The following is a description of a gene set: species: Homo sapiens Human Gene Set: AIZARANI_LIVER_C33_STELLATE_CELLS_2 from publication Aizarani N, Saviano A, Sagar, Mailly L, Durand S, Herman JS, Pessaux P, Baumert TF, Grün D (PMID 31292543), and this is the list of marker genes: ID3, ITGB1, NUDT4, ANTXR1, MGP, PHLDA1, EPB41L2, MCAM, NOTCH3, PLS3, GPX3, TPM2, SEMA5A, C7, BAZ1B, PAG1, LAMB1, DBNDD2, TIMP3, CCDC92, COL1A1, GNAS, CLMN, IGFBP7, RBPMS, CALD1, TPM1, ZFHX3, KANK2, GJA4, DLC1, ENAH, RBMS3, UACA, CAMK2N1, DST, CCDC3, COL3A1, NRXN1, ARHGEF17, IFITM2, BGN, PPP1R12B, SEPTIN4, RCAN2, NFIA, COL1A2, TSC22D1, MYH11, IMPA2, LHFPL6, NID1, ANK3, PTH1R, KLHL23, LUC7L3, CAVIN3, LPP, ISYNA1, SPARCL1, COL5A1, PELO (pelota mRNA surveillance and ribosome rescue factor), ID4, NEXN, RASD1, PLA2G5, ADAMTS1, LGALS1, PALLD, COL6A1, C11orf96, CYGB, PLAT, MAP1B, NT5DC2, TLN1, COL4A2, LAMC1, FXYD6, CRISPLD2, SOD3, ITGA7, CDC42BPA, CPE, TSPAN3, TOB1, COLEC11, TPM4, FLNA, PBX1, MBTPS1, OAZ2, ATN1, PXDN, MYH9, A2M, NR2F2, ATP1B3, COL4A1, ADGRF5, RGS5, LGI4, MEF2D, MYLK, TBX2, FIGN, MYL9, IGFBP5, CAV1, COL6A2, SPARC, ACTA2, ANXA6, CRYAB, TOB2, VIM, MXRA7, EBF1, SEPTIN11, PTN, ITGA1, PCM1, TNS1, CD59, EPAS1, PRKG1